Given this list of marker genes NRG1, DOLPP1 (dolichyldiphosphatase 1), RNASEL, TUBE1, CNOT6, HTATIP2, ARMC1, L3HYPDH, CFAP36, ADGRG6, ABCD3, POU5F2, SERPINA10, MTF2, KATNIP, SPOPL, SEPTIN10, PIN1, TBC1D23, SH2D5, CCT6A, PRRC1, CDC23, ENC1, DOCK7, LINC00639, NIPAL3, CNOT1, SCARA3, C2CD6, ZNF777, DNAJA4, OPN1SW, BDP1, ZMYM1, PRIM2, IWS1, LIPT1, PRDX4, UBXN1, XRCC5, CDC5L, CLCN3, NARF, LRFN1, LARS1, PIGK, CCDC77, ZNF614, MCAT, PABPC4, SLC4A11, ZBTB21, WDFY4, AP4E1, PPIL1 (NCBI Gene Id 5482), LFNG, HFM1 (NCBI Gene Id 374992), MAK16, UCHL5, DKK4, USP4, POC1A, SLC30A4, AUP1, CAPRIN1, SNAI1, SNORD8, CRNKL1, KLHDC10, THYN1, ASRGL1, TARDBP, LINC01310, PHLDB2, SUPT20H, VPS37A, CDC42SE2, DAB2IP, ZMAT1, SLC45A4 (NCBI Gene Id 57210), HAPSTR1, PSME4, MAPRE2 (NCBI Gene Id 51683), ZNF436-AS1, DUSP18, DHFR2, ENTPD6, IDE, KRTAP9-8, INTS6, FAM53B, ZFYVE16, DOCK6, CACNG1, KLHL34 (kelch like family member 34), ZNF557, WDR76 (NCBI Gene Id 79968), SREK1, ORC6, INE1, DOP1A, JADE1, MIGA2, PRL (NCBI Gene Id 5617), HSPA9, CAMSAP1, VAV1, ZNF684, ITGA9, NAP1L4, HMG20A, AKAP17A, KLF13, OSBPL8, JARID2, BYSL, PASD1, CX3CR1, HNMT, LCLAT1, ZBED5, THBD (thrombomodulin), GSTZ1, MAGED1, TRIM8 (NCBI Gene Id 81603), SLC46A3, ZCCHC14, RNF123, PPAN, ZNF18, MAPK1, HIP1, MCFD2, PPP4R3B, COPB2, ZNF134, CFAP20, ELAC1, ZNF438 (NCBI Gene Id 220929), KCTD18, JAM3, HES2, TRIML2, SLC25A27, ACOT4, FOXA1, MIB1, HAUS3, SLC30A2, CHD1, WDR43 (NCBI Gene Id 23160), INTS13, AP3M2, TUBGCP4, CRKL, EGR1, TMEM33, TMEM243, HAUS6, PHACTR2-AS1, NUDT12, SPTB, CSNK2A2, SLC38A2, MUC3A (mucin 3A, cell surface associated), TANC2, KLHL17, SOX3, ACTR6, FBXO32, NHLRC2 (NCBI Gene Id 54835), CTTNBP2, ZMYM2, ZNF682, MRAS, PBX3 (NCBI Gene Id 5090), NRGN, AP2A2, COL26A1, CD302 (NCBI Gene Id 9936), LARP4, DGLUCY, ELP1, CLTC, CEBPZ, GK3, POLR3E, MAP3K15, RBM33, RPE, THUMPD3, C19orf48P, KLHL12, CPSF2, here is a description of the gene set: Human Gene Set: GSE41867_NAIVE_VS_DAY15_LCMV_CONE13_EFFECTOR_CD8_TCELL_DN During acute viral infections, naïve CD8+ T cells differentiate into effector CD8+ T cells and, after viral control, into memory CD8+ T cells. Memory CD8+ T cells are highly functional, proliferate rapidly upon reinfection and persist long-term without antigen. In contrast, during chronic infections, CD8+ T cells become “exhausted” and have poor effector function, express multiple inhibitory receptors, possess low proliferative capacity, and cannot persist without antigen. To compare the development of functional memory T cells with poorly functional exhausted T cells, we generated longitudinal transcriptional profiles for each. Genes down-regulated in CD8 T cells: naïve versus effectors at day 15 chronic infection with LCMV-clone 13. species: Homo sapiens from publication Doering TA, Crawford A, Angelosanto JM, Paley MA, Ziegler CG, Wherry EJ (PMID 23159438)